The following is a description of a gene set: studied in species Homo sapiens Human Gene Set: GOBP_ESTABLISHMENT_OF_SISTER_CHROMATID_COHESION The process in which the sister chromatids of a replicated chromosome become associated with each other during S phase., and this is the list of marker genes: SMC1A, DDX11L8, STAG1, STAG3, DDX11, DDX12P, STAG2, NIPBL, SMC3, RAD21, NAA50